The following is a description of a gene set: Mouse Gene Set: GOBP_CD4_POSITIVE_ALPHA_BETA_T_CELL_DIFFERENTIATION species: Mus musculus The process in which a relatively unspecialized T cell acquires specialized features of a mature CD4-positive, alpha-beta T cell., and this is the list of marker genes: Batf, Malt1, Stat6, Zfp35, Gimap5, Ascl2 (NCBI Gene Id 73698), Tnfsf4, Il6, Pf4, Ccl19, Pik3r1 (phosphoinositide-3-kinase regulatory subunit 1), Il6ra, Gata3, Jak3 (NCBI Gene Id 16453), Il4ra, Ccr7, Cd83, Klhl25, Entpd7, Nfkbiz, Ccr2, Il18, Ly9, Prkcz, Anxa1, Sash3, Rc3h2 (ring finger and CCCH-type zinc finger domains 2), Rara, Ccr6, Il12b, Ctsl, Cd69, Irf4, Mtor, Ccl20, Runx3, Nkx2-3, Nlrp3, Sh3rf1, Socs1, Zc3h12a, Irf1, Nckap1l, Il18r1, Otud5, Bcl6, Mir326, Tox, Men1, Relb, Nfkbid, Zbtb7b (NCBI Gene Id 22724), Tgfb1, Lgals1, Armc5 (NCBI Gene Id 260394), Fut7, Stat3, Rsad2, Il23a, Ptger4, Braf, Rora, Il2rg, Ep300, Il21, Brd4, Tmem98, Loxl3, Tbk1, Atp7a, Gpr183, Foxp1, Mir873a, Gimap1, Stat4, Sema4a, Cbfb, Ncor1, Il2, Slamf6 (NCBI Gene Id 80894), Runx1, Il27, Spn, Hmgb1, Gimap3, Kmt2a, Il4, Foxp3, Brd2, Rorc, Lef1, Rc3h1, Kcnk18, H2-Ea, Smad7, Ripk2, Cracr2a, Pla2g2d, Pax1, Bcl3, Satb1, Mir301, Shb, Opa1, Tnfsf18, Ifng, Tbx21, Myb, Hlx, Socs5, Gadd45g